The following is a description of a gene set: Reactome Pathway: Release of apoptotic factors from the mitochondria part of: Apoptotic factor-mediated response Apoptotic factors released from the mitochondria promote apoptosis through several different mechanisms. Cytochrome C participates in Apoptosome driven effector caspase activation while SMAC relieves IAP mediated caspase inhibition. species: Homo sapiens, and this is the list of marker genes: SEPTIN4, CYCS, GSDMD, BAK1, GSDME, DIABLO (diablo IAP-binding mitochondrial protein), BAX